Given this list of marker genes B4GALT3, CERT1, LCT, DEGS2, SPTLC2, FUT4, OSBP, TLCD3B, SMPDL3A, ST3GAL5, PRKD2, SCARB2, UGT8, ST8SIA3, CLN8, ST6GALNAC5, FUT2, B3GALNT1, C20orf173, ELOVL1, PNPLA1, SGPP2, ORMDL3, NAGLU, B3GNT5, CERS6, ST3GAL2, ST8SIA5, PLPP1, NEU4, HACD3, ABCA2 (NCBI Gene Id 23153), LARGE1, B3GALT4, CERS3, ELOVL7, B4GALNT1, PRKAA1, SPNS2, FUT7, SMPD2, ST8SIA4, SMPD4, GALC, M6PR, CERK, NEU3, CERS2, ZPBP2, TEX2, NAAA, B4GALT5, CERKL, VPS54, B3GALT1, SAMD8, CERS1, ENPP7, SFTPB, TECR, BAX, FUT9, SPTSSA, GBA1, CEL, SMPD1, PSAPL1, B4GALT6, P2RX7, ST8SIA1, SGMS1, HTRA2, CERS5, ACER2, PAQR4, ST3GAL1, ASAH1, PPM1L, ST8SIA6, SMPD3, ALDH3B1, P2RX1, FA2H, KIT, ST6GALNAC6, HACD1, ST6GALNAC4, CLN6, SGMS2 (NCBI Gene Id 166929), PLPP2, ELOVL6, NSMAF, SERINC1, CERS4, ACER1, SPHK2, HEXB, KDSR, GLB1, MIR195, ZNF750 (zinc finger protein 750), ABCG2, MFSD2B, GM2A, ITGB8, ASAH2, SGPP1, HEXA, CREM, CSNK1G2, SPHK1, ALDH3B2, ELOVL2, PEMT, ELOVL4, HACD4, CYP4F22, ENPP2, NEU2, B4GALT4, B3GALT2 (beta-1,3-galactosyltransferase 2), GLA, ST8SIA2, ORMDL2, AGK, A3GALT2, SIRT3, ELOVL3, ORMDL1, ABCC1, ELOVL5, UGCG, GAL3ST1, CCN1, ASAH2B, DEGS1, FUT3, SPTLC3, SMPDL3B, VAPA, HACD2, PRKCD, PLA2G6, FUT5, SPTLC1, ST3GAL3, TM9SF2, FUT6, MECR, ETNPPL, A4GALT, ARV1, ST6GALNAC3, PLPP3, ABCA12, FADS3, PLA2G15 (phospholipase A2 group XV), PPT1, ALOX12B, ACER3, NEU1, PSAP, SPTSSB, SGPL1, GBA3, GBA2, PRKD1, FUT1, MIR16-1 (NCBI Gene Id 406950), ABCA8, PRKD3, MIR127, ALOXE3, SUMF1, here is a description of the gene set: Human Gene Set: GOBP_SPHINGOLIPID_METABOLIC_PROCESS The chemical reactions and pathways involving sphingolipids, any of a class of lipids containing the long-chain amine diol sphingosine or a closely related base (a sphingoid). species: Homo sapiens